The following is a description of a gene set: A simultaneous engagement of different pathogen recognition receptors provides a tailor made adaptive immunity for an efficient defence against distinct pathogens. For example, cross talk of TLR and c-type lectin signalling effectively shapes distinct gene expression patterns by integrating the signals at the level of NF-κB. Here, we extend this principle to a strong synergism between the Dectin-1 agonist, curdlan, and an inflammatory growth factor, GM-CSF. Both together act in synergy in inducing a strong inflammatory signature which converts immature DCs to potent effector DCs. A variety of cytokines (IL-1β, IL-6, TNF-α, IL-2 and IL-12p70), costimulatory molecules (CD80, CD86, CD40 and CD70), chemokines (CxCl1, CxCl2, CxCl3, CCl12, CCl17) as well as receptors and molecules involved in fugal recognition and immunity such as Mincle, Dectin-1, Dectin-2 and Pentraxin 3 are strongly up-regulated in DC treated simultaneously with curdlan and GM-CSF. The synergistic effect of both stimuli resulted in strong IKBα phosphorylation, in its rapid degradation and in enhanced nuclear translocation of all NF-κB subunits. We further identified MAPK ERK, as one possible integration site of both signals, since its phosphorylation was clearly augmented when curdlan was co-applied with GM-CSF. Our data demonstrate that the immunomodulatory activity of curdlan requires an additional signal provided by GM-CSF to successfully initiate a robust β-glucan specific cytokine and chemokine response. The integration of both signals clearly prime and tailor a more effective innate and adaptive response against invading microbes and fungi. studied in species Homo sapiens Human Gene Set: GSE32986_CURDLAN_HIGHDOSE_VS_GMCSF_AND_CURDLAN_HIGHDOSE_STIM_DC_DN Genes down-regulated in bone marrow-derived dendritic cells: high dose of 1,3-beta-D-oligoglucan versus CSF2 and high dose of 1,3-beta-D-oligoglucan. from publication Min L, Isa SA, Fam WN, Sze SK, Beretta O, Mortellaro A, Ruedl C (PMID 22250091), and this is the list of marker genes: NFKBIA, B3GALNT2, KDM6B, PPP1R15A, TBC1D8, DUSP2, FILIP1L, ICOSLG, NLRP3, HERPUD1, BRI3BP, REL, CSRNP1, ACOD1, ZBED3, PTGER4, IL10RA, RPL19, SPAG6, MED13L, IFT57, MTMR14, RFX5, DNAJA2, N4BP1, ETS2, SOD2, RELB, TNFRSF1B (TNF receptor superfamily member 1B), PIM1, NECTIN1, CD69, RCAN1, SNN, ITGA5, EHD1, PDE4B, CXCL1, LCP2, TAGAP, CHDH, CCDC87, SPNS3, MLLT6, LMO4, GEM, KCNV2, ZC3H12A, RALGDS, JARID2, CCRL2, MMP17, DYRK2, UBE2F, CCL4, FCHSD2, IRAK2, GRK3, SKIL, RUNDC3A, HES7, OLR1, TNFSF9, NR4A1, TNFAIP2, PTPN6, RARRES2, SPIC, CD40, ZRANB2, MEFV (MEFV innate immunity regulator, pyrin), EGR1, HDAC1, MAPKAPK2, TSPAN15, ZEB1, RASGEF1B, BRPF1, PSPC1, EGR3, SLC2A6, CCR7, PPP1R11, TNF, EML4, ISG15, SNHG17, GPR84, BIRC3 (NCBI Gene Id 330), VASP, CFLAR, ADAM17 (ADAM metallopeptidase domain 17), SDC4, SPATA13, PRDM1, DUSP1, SNRPD3, RNF19B, NCF4, PTGIR, U2SURP, MIER3, TNFAIP3, IRF1, CASP4, PKIG, TRIM69, CCSER2, CIITA, CLEC4E, HLA-B, MARCKSL1, CXCL3, PRRC2A, HCK, RPS18, DUSP5, ARHGEF37, PLEKHO2, FPR2, JUNB, MRAP2, RRAD, FNDC4, SAMSN1, DLGAP2, SERPINB9, NFKBIZ, HLA-DRB1, TRAF3, KCTD11, IL1B, NFKBID, RASSF4, SOCS3, MMP14, CNFN (cornifelin), JAK2, STX11, NR4A3, RAB20, ZFP36, SLC44A2, APEX1, NFKBIE, IL1A, PTPRJ, TLR2, SWAP70 (switching B cell complex subunit SWAP70), CNN3, ZNF516, NOL7, STAT5A, ZC3H12C, FNBP1, PTGS2, CD83, IL1RAPL2, NUPR1, BCL11A, PPP6R1, GPR132, IKBKE (inhibitor of nuclear factor kappa B kinase subunit epsilon), SCIN (NCBI Gene Id 85477), CDC42EP2, CALHM6, HIVEP3, SPRED1, RELA, ABITRAM, SLFN12L, ICAM1, TRAF1, MAFF, BCL3 (BCL3 transcription coactivator), FBRS, DDR1, NFKB1, TNIP1, IL4I1, SLC31A2, LIMD2, MOB3A, ZC3H7B, SEMA6D, PSTPIP2, CD86, SLC30A4, CCL22, CLRN3, GADD45B, CAND1, NFKB2, CXCL10, SUB1, AEBP2 (AE binding protein 2), DENND4A, FAS, FOXP4, PPFIBP2